The following is a description of a gene set: studied in species Homo sapiens Human Gene Set: REACTOME_ASPARTATE_AND_ASPARAGINE_METABOLISM Aspartate and asparagine metabolism, and this is the list of marker genes: GADL1, GOT1, NAALAD2, ASNS, NAT8L, FOLH1, ASPG, ASPA, SLC25A13, SLC25A12, GOT2